The following is a description of a gene set: studied in species Homo sapiens Human Gene Set: MYCMAX_03 Genes having at least one occurrence of the motif NNNNNNNCACGTGNNNNNNN in the regions spanning 4 kb centered on their transcription starting sites. This matches the MYC, MAX transcription factor binding site V$MYCMAX_03 (v7.4 TRANSFAC)., and this is the list of marker genes: ANKRD17, SIGMAR1, EPC1, CELF1, SYNCRIP, POU3F2, NUP62CL, GLB1L, PTMA (prothymosin alpha), MRPL27, ADAM12, DIP2B, HOXA11, HSP90B1 (heat shock protein 90 beta family member 1), RALYL, LRRC59, MARCHF8, CEBPB, ASPHD1, TAOK2, KANSL1L, SHOC1, GGN, EIF4G1, SMC3, DCTN4, BOK, FBXL19, SYT3, TAF6L (NCBI Gene Id 55310), HOXB5, NEURL2, COPZ1, BMP6, CLIP2, EIF3A, MANF, ZNF318, HAPSTR1, B3GALT2, PLCG2, UBXN6, LEF1, TAC1, TRMO, HMOX1, PLEKHA6, C1orf43, PCED1A (NCBI Gene Id 64773), MICU1, PABPC1, USP15, ZMYND12, QTRT2, AKAP1, TMEM132E, FBXL19-AS1, HOXD10, AMDHD2, GADD45G, DYM, NEUROD1, RSPRY1, UBXN10, ALDH6A1, NEUROD2, NPTX1, PDIA2, TXNDC12, PKN1, PER1, IGF2R, GJA1, SPINK5, UCHL1, GPC3, TFAP4, HNRNPA1, TIMM8A, GIGYF2, RNF146, AMMECR1L, CTSF, DRD1, RMND1, TOPORS, SLC38A2, PFDN2, IRF9, UBE2B, ARPC5, DNMT3A, TOM1, OLFM2, TADA1, HOXC5, UTP14A, NR1D1, GNAS, RPS28 (ribosomal protein S28), PPM1A, CITED2, PPCS, KCNK5, SIRT1, OPRD1 (NCBI Gene Id 4985), LAMP1, RAB3IL1, SEC23IP, MCM2, HOXA9, ILF3-DT (ILF3 divergent transcript), TEF, RPA1, SOCS5, SSR1, TESK2, EME1, SPPL3, H3-3A, MIA2, HOXA1, FMR1, SNCAIP, ANKHD1-EIF4EBP3, HNRNPD, SLC17A9, RBBP4, VPS33A, HEXA, KRTCAP2, GABARAP, NPM1, OBI1, CLUH, TRIM37, LONRF3, NRIP3, XPO1, PPRC1, KCNH4, SNX16, PRDM4, AP1S2, KAT5, BAX, B3GNT9, DUSP7, ZBTB8OS, VPS16, RRAGB, IGF2BP1, DENND6A, FKBP11, IRS4, HNRNPA3, RLF, DDX3X, AFF4, PRKCG, MGME1, ATP6V1C1, BMP7, SLC1A7 (solute carrier family 1 member 7), CPT1A, OGDHL, MEOX2, UBE4B, TMEM132E-DT, ATF4, SNX5, SPNS1, ZIC1, PBRM1, CREBRF, PLAGL1, RGL1, CBX6, MTFP1, ZNF503, HOXB4, PHF20L1, ESRP2, LIN28A, CUL5, ALDH3B1, CCDC191, PCDHA10, PDP2, TBC1D15, ZCCHC7, RPL13A, PRPS1, CBX5, ILF3, ELAVL3, SCRT2, KDM6A, TGFB2, NR0B2, SLCO1C1, DEPDC7, PTGES2, FOXO3, STMN1, EIF4E, MAT2A, ANKHD1, KAT6A, BRD2, PHF20, RELB, COMMD3, VPS37B, PICALM, CDC14A, EPB41, NIT1, CTSA (cathepsin A), ARHGAP45, EIF4B, SYT6, CBX8, PSME3IP1, TRIB1, CIPC, CDKN2C, DLX2, SASH3, UTY, RBM15B, DNAAF6, PAX6, SEPTIN3, HOXA7, NDUFA7, ADAMTS3, PABPC4, CHST11 (carbohydrate sulfotransferase 11), SLC38A5, GTF2A1, SCYL1, CELSR3, CCAR1, CD164, ARMT1, CUTA, SMYD4, HOXB7, ODC1, CACUL1, LYPD1, REXO2, PTCH1, TGIF2, NFX1, LIG3, SHMT1, CHD4, GATA5, CYP2D6, RAB30, KBTBD2, ADSS2